The following is a description of a gene set: The process whose specific outcome is the progression of the cerebellar Purkinje cell layer over time, from its formation to the mature structure. The Purkinje cell layer lies just underneath the molecular layer of the cerebellar cortex. It contains the neuronal cell bodies of the Purkinje cells that are arranged side by side in a single layer. Candelabrum interneurons are vertically oriented between the Purkinje cells. Purkinje neurons are inhibitory and provide the output of the cerebellar cortex through axons that project into the white matter. Extensive dendritic trees from the Purkinje cells extend upward in a single plane into the molecular layer where they synapse with parallel fibers of granule cells. Mouse Gene Set: GOBP_CEREBELLAR_PURKINJE_CELL_LAYER_DEVELOPMENT species: Mus musculus, and this is the list of marker genes: Herc1, Aars1, Nfix, Lhx1, Ldb1, Klhl1, Whrn, Naglu, Atp2b2 (NCBI Gene Id 22426), Kif14, Ttll1, Rora, Cend1 (cell cycle exit and neuronal differentiation 1), Coq8b, Sptbn2, Myh10, Dll1, Sez6l, Rere, Gba1, Ttc21b, Skor2, B4galt2, Lhx5, Atxn2, Psap, Uqcrq, Cntnap2, Atg7, Foxp2, Atp7a, Cacna1a (calcium channel, voltage-dependent, P/Q type, alpha 1A subunit), Sez6l2, Slc25a46, Hspa5, Sez6, Faim2, Arcn1, Agtpbp1